Given this list of marker genes BTG2, TSR2, MMP2 (matrix metallopeptidase 2), IMP3, KLF2, FLVCR2, PTGS2, FBL, CDX4, UTP4, NOG, FTSJ3, SHMT1, CEBPB, FITM2, ZNF622, PTRH2, MARS1, PPP1R14A, BOP1, PFKFB3, WDR46, HSDL1, PES1, AP3M1 (NCBI Gene Id 26985), JUNB, FST, MRPS26, SGK1, DRG2 (NCBI Gene Id 1819), TCIM, ATF3, CYP27B1, MRPL12, SAMM50, FTSJ1, AGK, PTGES2, NOP9, MRPL22, PPM1H, TSFM, SAT1, HSPA4, SLC16A6, EGR1, ANGPTL7, PDLIM3, H3C2 (H3 clustered histone 2), CHCHD10, CCN1, IGFBP1, PTP4A3, MCMBP, NLE1, HAUS2, B3GNT2, WDR12, TUBA8, ANGPTL3, TXNIP, PTPMT1, CRLS1, RPS27L, SPIDR, CTH, RBP4 (NCBI Gene Id 5950), PHLDA2, TMA16, FOS, MAGOHB, GATD3, PHB2, MEGF6, BOLA3, CYP51A1, SERPINH1, FOXO3, RGCC, ZNF330, LYRM1, RERG, EMC8 (NCBI Gene Id 751), BUD23, SNAI1, ADAM10, HSP90AA1 (heat shock protein 90 alpha family class A member 1), MRPS18A, DNTTIP2, ATP5IF1, VRK2, STARD10, NOL6, TMEM106B, UTP3, MYBBP1A, PDSS1, MRPS18B, ETF1, IGF2, RRS1, TP53INP1, HTRA2 (NCBI Gene Id 27429), SIX2, DUSP4, RNASET2, REXO2, EIF4E, NSUN2 (NCBI Gene Id 54888), SSR1, ODC1, BRF1 (BRF1 RNA polymerase III transcription initiation factor subunit), GPD1, KRT17, BAX, TP53, JDP2, C6, IMPDH1, IMP4, BMP2, NOL7, CCNG2, MIX23, VPS9D1, HSPA9, EIF6, CYP24A1, DDX19A (NCBI Gene Id 55308), HEATR3, SEC23B, DDX51, DUSP5 (dual specificity phosphatase 5), TOB1, NOC4L, MBLAC1, TSPAN18, MYOG, MANF, NOL8, CIC, PINX1, CCNG1, SPINK5, MKNK2, ZPR1, SLC12A3, HES1, DNAJA3, PWP1 (PWP1 homolog, endonuclein), GADD45B, ID2, MDM2, POP4, TOMM20, RCAN1, RPF2, HSPA1L, HARS2, WRAP73, ING5, SLC12A7, DDX49, FN1, RRP9, ZNF593, EPRS1, JUN, NMRK2, MS4A4A, HIGD1A, NIP7, CLDN4, AKR7A2, GAR1, TAF9, CORT, PIM1, RNF144B (ring finger protein 144B), TSR1, PLK3, OLA1, CYP26A1 (NCBI Gene Id 1592), CASP8, AK4, GCNT4 (NCBI Gene Id 51301), SRPRB, RASL11B (NCBI Gene Id 79093), ELOVL1, RPL10L, TRMT1, KLF11, AP1M2, SLC3A2, POLR1E, S100A8, MIDN, IFFO1, MRPL52, MAGEE1, PPAN (NCBI Gene Id 84997), ANKRD22, ABCF2, PARP3, MMP9, here is a description of the gene set: A major goal of cancer research has been to identify genes that contribute to cancer formation. The similar pathology between zebrafish and human tumors, as well as the past success of large-scale genetic screens in uncovering human disease genes, makes zebrafish an ideal system in which to find such new genes. Here, we show that a zebrafish forward genetic screen uncovered multiple cell proliferation mutants including one mutant, crash&burn (crb), that represents a loss-of-function mutation in bmyb, a transcriptional regulator and member of a putative proto-oncogene family. crb mutant embryos have defects in mitotic progression and spindle formation, and exhibit genome instability. Regulation of cyclin B levels by bmyb appears to be the mechanism of mitotic accumulation in crb. Carcinogenesis studies reveal increased cancer susceptibility in adult crb heterozygotes. Gene-expression signatures associated with loss of bmyb in zebrafish are also correlated with conserved signatures in human tumor samples, and down-regulation of the B-myb signature genes is associated with retention of p53 function. Our findings show that zebrafish screens can uncover cancer pathways, and demonstrate that loss of function of bmyb is associated with cancer. Human Gene Set: SHEPARD_CRASH_AND_BURN_MUTANT_UP studied in species Homo sapiens Human orthologs of genes up-regulated in the crb ('crash and burn') zebrafish mutant that represents a loss-of-function mutation in BMYB. from publication Shepard JL, Amatruda JF, Stern HM, Subramanian A, Finkelstein D, Ziai J, Finley KR, Pfaff KL, Hersey C, Zhou Y, Barut B, Freedman M, Lee C, Spitsbergen J, Neuberg D, Weber G, Golub TR, Glickman JN, Kutok JL, Aster JC, Zon LI (PMID 16150706)